The following is a description of a gene set: Mouse Gene Set: GOBP_POSITIVE_REGULATION_OF_PHOSPHORUS_METABOLIC_PROCESS species: Mus musculus Any process that increases the frequency, rate or extent of the chemical reactions and pathways involving phosphorus or compounds containing phosphorus., and this is the list of marker genes: Raf1, Enpp2, Rap1a, Ddr2, Rad50, Hcls1, Eno1, Rassf2, Sdcbp, Cass4, Apln, Cemip, Hif1a, Tirap, Mapk1, Sirt1, Wee2, Wnt1, Ercc6, Map3k12, Ndufc2, Akap9, Gapdhs, Zfp91, Ccnd2, Tgfb2, Prxl2c, Gpnmb, Bdnf, Akt1, Prkcd, Cdk5, Tlr6, Psmd10, Ntrk1, Ppp1r15a, Ripk1, Npnt, Xrcc5, Brat1, Avpr1b, Dusp19, Acvr1, Pik3r5, Efna1, Chek2 (checkpoint kinase 2), Capn2, Chrna3, Prkn, Drd1, Kif14 (kinesin family member 14), Adipoq, Sox9, Rap2c, Il3, Zeb2, Kat2b, Mas1, Gpr39, Ptk2b, Ptger3, Adcyap1, Cripto, Csf2, Adam9, Nbn, Fbh1, Pik3r1, Fas, Apoc2l, Stradb, Uchl1, Ccdc88a, Clspn, Chp1, Adora2b, Map2k4, Hras, Mob2, Map3k10, Map3k5, Ppia, Mmp9, Gfra1, Gsk3a, Spatc1l, Ezh2, Ddrgk1, Pde4d, Ngf, Trim6, C3, Cd74, Ptprc, Crlf1, Tnfsf11, Cacul1, Map2k6 (mitogen-activated protein kinase kinase 6), Rspo1, Tead1, Slc1a1, Adcyap1r1, Dynap, Lrp4, Cd4, Cntf (ciliary neurotrophic factor), Kit, Cdk2ap1 (NCBI Gene Id 231728), Plek (NCBI Gene Id 69998), Itga5, Fgf1, Psen1 (NCBI Gene Id 19164), Wnk3, Aktip, Cdk5r1, Dhx34, Fbn1, Sh2d1b2, Cenpe, Jtb, Musk, Cryaa, Plpp3, Edn1, Xbp1, Ifng, Lmo4, Ang4, Mlst8, Kndc1, Avp, Lck, Flt3l, Ajuba, Mif, Wnk4 (WNK lysine deficient protein kinase 4), Sesn2, Arhgef5, Limch1, Anxa2, Rac1, Efna5, Spn, Adrb2 (NCBI Gene Id 269028), Fiz1, Ccl19-ps4, Cntn1, Bmpr2, Cd40, Nptn, Il2, Araf, Erbb4, Pxn, Ptprz1, Irgm1, Camp, Rap2b, Pink1, P2rx7, Sphk1, Pim1, Lilra5, Pid1, Eno1b, Pak2, Adora1, Tpd52l1, Ins2, Gnas, Park7, Tigar, Ralbp1, Ogt, Psrc1 (NCBI Gene Id 99778), Prkca, Pdgfra, Lep, Tnf, Mprip, Rgma, Iqgap1, Rb1cc1, Abi1, Tfrc (transferrin receptor), Akap5, Ppargc1b, Hnf1a (NCBI Gene Id 21405), Ang, Mapk9, Crh, Ednrb, Mtor, Hax1, Chi3l1, Lats1, Gsk3b, Dvl2, Fgf4 (NCBI Gene Id 14175), Wnt5a, Atg14, Lrp8, Met, Cib1, Adnp, Insr, Ccny, Hdac6, Daxx, Tnk2, Pth1r, Ccl19-ps6, Fbxw7, Rack1, Sema4d, Arrb2, Sqstm1, Crkl, Il6st, Mapre3, Dynapl1, Bend3, Sh2d1b1, Il1b, D1Pas1, Pdgfa, Axin1, Itgb1bp1, Fgf7, Crebl2, Clec7a, Dscam, Ang2, Csf3, Rab38, Grk1, Ang6, Ptafr, Rps3, Cx3cr1, Card14, Cdk5r2, Ccl5, Ehd4, Rasa1 (RAS p21 protein activator 1), Mre11a, Adgrf5 (adhesion G protein-coupled receptor F5), Spdya, Taok3, Dock7, Cspg4, Ntf3, Tnfrsf11a, Fzd5, Tcim, Lhcgr, Ilk, Fzd8, Srcin1, Cd24a, Yes1, Ppara, Bag4, Clcf1, Als2, Gpi1, Ccr7, Rgcc, Fgfr1, Htr2c, Cimap3, Egf (NCBI Gene Id 99717), Ang5, Il34, Mapkap1, Tab2, Gck, Fnip1, Agt, Gab1, Prkaa2, Adcy10 (NCBI Gene Id 73777), Tnfrsf1a, Gdnf, Pik3ca, Arnt, Dok7, Cd80, Nkx3-1, Oprd1 (opioid receptor, delta 1), Igbp1, Tnfrsf18, Ip6k2, Ager, Pibf1, Clip3, Trim65, Dab2, Map3k7, Adipor2, Cln3, Acvr2a, Adam17, Hmgb1, Unc119, Nrg1, Nrp1, Nos3, Mlx, Nox4, Myc, Syk, Ltf, Stox1, Arl2bp, Ralb, S1pr2, Sash1, Rock1, Fcer1a, Tmsb4x, Il13, Smyd3, Nos1, Traf4, Fgf15, Rock2, Ect2, Angpt4, Pecam1, Il4, Esrrb, Cab39, Tsacc (NCBI Gene Id 76927), Sez6, Bmp6, Prr5, Parp14, Plcd1, Agrn, Kitl, Reg3b, Il12b, Mt3, Il18, Chga, App, Myh9, Fgf2, Dvl1, Vcp, Igf1, Ceacam1, Bank1, Grb10, Cops8 (COP9 signalosome subunit 8), Itgb1, Wnt3a, Ttbk1, Lyn, Stil, Ptpn5, Epo, Il31ra, Limk2, Reg1, Fabp3, Bcar3, Dtnbp1, Eif4g3, Cav2, Lif, Traf6 (TNF receptor-associated factor 6), Adtrp, Areg, Ep300, Syap1, Braf (NCBI Gene Id 97330), Mst1r, Tom1l1, Akap6, Adcy8, Nrxn1, Pdgfrb (platelet derived growth factor receptor, beta polypeptide), Nr1h4, Dlg1, Txn1, Spdye4a, Vtn, Map2k2, Mapk8ip3, Map3k1, Fgf8 (NCBI Gene Id 14179), Jak2, Erbb2, Traf2, Ntrk3, Vldlr, Cldn19, Cartpt, Ednra, Cdkn1b, Axin2, Cdc25b, Trpc5, Cx3cl1, Itln1, Vegfa, Pth, Il24, Tm9sf5, Plaur, Prkd1, Mavs, Hdac3, Map3k11, Kras, Kdr, Spry2, Fam20a, Flt3, C1qtnf9, Mad2l2, Il6, Dstyk, Chrna7, Parp9, Thpo, Hes1, Pih1d1, Mapk15, Faxdc2, Zfp622, Erp29, Arhgef2 (NCBI Gene Id 99482), Aplnr, Cxcr4, Ccn2, Nedd9, Thbs1, Mef2c, Trf, Wdr24, Rapgef2, Chp2, Ppp2r3c, Map2k7, Slco3a1, Nckap1l, Cd44, Ptges3, Ucn, Glmn, Tgfb1, Ar, Stk4, Bcl2l1, Fgf18, Map4k2, Eif4g1, Cd244a, Lepr, Rictor, Etaa1, Rapgef3, Pcx (pyruvate carboxylase), Edn3, Gata1, Il11, Sez6l2 (NCBI Gene Id 233878), Cd6, Pin1rt1, Acsl3, Fzd1, Ntsr1, Apoc2, Prom2, Hspa2, Enpp7, P2ry1, Irak1, Camk1, Il15, Tbx1 (NCBI Gene Id 21380), Prkag2, F2, Lrrk1, Rap2a (RAS related protein 2a), Il23a, Ntrk2, Osm, Tcl1, Inhba, Flt4 (FMS-like tyrosine kinase 4), Nek10, Tesk1, Ddx3x, Fmr1, Angpt1, Fzd7, Thbs4, Mlxipl, Neurl1a, Ccl19-ps5, Sez6l, Robo1, Tlr4, Tnik, Lrrn3, Pdgfc, Card10, Dab1, Trem2, Akap11, Abi3, Sik2, Grk3, Camkk2, Csnk1d, Rarres2, Tgfa, Irs1, Slc11a1, Cdk2ap1rt, Fzd4, Niban1 (NCBI Gene Id 98556), Mrnip, Higd1a, Gper1, Tspan9, Adra2b, Ptpn11, Prr5l, Tlr1, Drd4 (NCBI Gene Id 13491), Ccnd1, Prox1, Gprc5b, Vegfc, Pdgfb, Abi2, Ern2, Hsp90aa1 (NCBI Gene Id 15524), Il21, Ppp2ca, Pfn2 (NCBI Gene Id 18645), Ptpn1, Nod2, Xrcc6, Flt1, Vangl2, Il12a, Hipk2, Slc25a12 (solute carrier family 25 (mitochondrial carrier, Aralar), member 12), Ptk2, Bcl2, Map3k13, Hpx, Map2k1, Ereg, Bcl10, Phip, Stat3, Pdcd10, Mmd2, Adra2c, Pik3r3, Akt2, Wdr59, Hbegf, Gas6, Gpld1, Fyn, Map3k4, Itga6, Il6ra, Osbp, Ctnnd1, Prnp, Sema7a (sema domain, immunoglobulin domain (Ig), and GPI membrane anchor, (semaphorin) 7A), Irgm2, Eif2ak4, Ccn1, Snca, Tnfsf18, Pou1f1, Eng, Peli2, Fgf10, Pik3r6, Tab1, Hmga2, Atf2, Htr2a, Aif1, Tnfrsf14, Stk11, Epha4, Snx9, Fndc1, Bmp2, Dgkq, Ube2k, Isl1, Magi3, Slc4a4, Igtp, Ifnb1, Src, Agap2, Plk1, Tek, Ighm, Pak1, Ctf1, Csf1, Ripk3, Iqgap3, Cldn3, Flot1, Ccl19-ps1, Mtmr9, Hsf1, Lrrk2, Trpc6, Adra2a, Rhoa, Odam, Cdon, Pde5a, Wdfy2, Ripk2, Hdac2, Mydgf (NCBI Gene Id 28106), Npm1, Fgd4, Il5, Cnot9, Spata18, Egfr, Fgfr3, Map2k3, Ccnd3, Hes5 (NCBI Gene Id 15208), Ccl19, Tnks1bp1, Pin1, Vegfb, Dab2ip (disabled 2 interacting protein), Cav1, Gpd1, Fgd2, Emp2, Pla2g6, Arrb1, Bmp4, Prlr, Ern1, Kctd20, Mmd, Abl1, Tenm1, Fnip2, Senp2, Ptger4, Maged1, Strada, Rptor, Ret, Cck, Slc8a2, Reln (NCBI Gene Id 19699), Notch2, Ptges3-ps, Zbtb20, Htr2b, Cd3e, Ccl19-ps3, Csf1r, Cdkn1a, Pfkfb1, Eef1a2, Grem1, P2ry6, Rasgrp1, Itgb3, Tpx2, Pik3cg, Icam1, Dvl3, Ins1, Prkaa1